The following is a description of a gene set: Mouse Gene Set: MIR_30A_3P_MIR_30E_3P from publication Chen Y, Wang X (PMID 31504780) species: Mus musculus Genes predicted to be targets of miRBase v22 microRNA mmu_miR_30a_3p, mmu_miR_30e_3p in miRDB v6.0 with MirTarget v4 prediction scores > 80 (high confidence targets)., and this is the list of marker genes: Ppp6r2, Sfmbt2, Slitrk3, Kcnb1, Ptpn21, Zfhx3, Slitrk2, Sema3d, Zfp84, Zfp937, 2610528J11Rik, Hcls1, Bche, Zfp612, Pdss2, Relt, Emc4 (ER membrane protein complex subunit 4), Prkacb, Kpnb1, Suco, Trim33, Tmem47, Myo5a, Dgkk, Pde5a, Capn6, Gnl1, Hhip, Dhx9, Magea2, Ninl, 5730480H06Rik, Zfp827, Adamts5, Mecp2, Zc3h14, Rela, Chpt1, Qtrt2, Wrn, Rgs7bp, Slc25a24, Shprh (NCBI Gene Id 70331), Gpr158, Hace1, Hcfc1, Rmi2, Tirap, Sh3gl3, Ccdc80 (coiled-coil domain containing 80), Themis, Macir, Lancl3, Tfrc (transferrin receptor), Nr1d2, Cebpzos, Prkaa2, Ralgps1, Acyp2, Ccdc184, Col12a1, Arid4a, Ube2j1, Ube2g1, Rock2, Csnk1g3, Cpsf2, Ube2f, Trim34a, Anapc10, Zbtb41, Ryr3, Phip, Npy2r, Fat1, 4930579G24Rik, Zfp81, Igf1, Pclo, Rpap3, Tshr, Sun2, Sh3glb1, Hadh, Cdh6, Msr1, Ttpal (tocopherol (alpha) transfer protein-like), Fndc5 (fibronectin type III domain containing 5), Ankrd26, B4galt6, Rala, Aqp4, Arx, Cbfb, Ap4e1, Cdk14, Mcm8, Mug2, Dennd1b, Donson, Lhfpl3, Trhr, Htr2a (5-hydroxytryptamine (serotonin) receptor 2A), Nol4, Lrrtm2, Cep162, Trem1, Col1a2, Luc7l3, Fut9, Ralb (NCBI Gene Id 80581), Itga4, Gne, Mbd1, Hpgd, Csnk1e, Atp8a1, Med12l, Sgms2, Hsf3, Cdadc1, Tnfaip1, Kcna2, Tab3, Rab11fip2, Traf3ip2, Fchsd2, Nufip2, Zfp980, Psd3, Tigd4, Nfkb1, Sh3bgrl2, Papss2, Tspyl1, Cadm2, Slc24a2, Nup153, Ildr2, Fam13c, Hira, Six4, Ttr, Ptpn3, Il1rn, Rgs7, Apc, Rarb, Acsm5, Nap1l2, Stox2, Stau1, Zfp558, Zbtb18, Rtl3 (NCBI Gene Id 213436), Bmp5 (NCBI Gene Id 12160), Lifr, Ptar1, Npffr2, Pno1, Kmt2a, Slc12a6, Hmga2, Etfrf1, Serpine1, Nr2c2, Stim2, Adamts9, Slc25a33, Hmgcll1, Mbnl3, Ror1, Ermn, Rex2, Smim11, Syne1, Antxr2, Atxn3, Ss18, Paip2, Zfp600, Egr1, Cdk17, Tnrc6b (NCBI Gene Id 72625), Pank2, D630039A03Rik, Ppt1, Mnt, Dennd4c, Ccn3, Ssbp2, Erap1, Naa15, Cyth3, Nabp1, Dnajb4, Serpinb8, Tmem140, Cdc73, Ctag2, Robo1, Ipo5, Smu1, Ubr5, Prkd3, 9530002B09Rik, Dock11, Tbx4, Cacybp, Tead1, Tril (NCBI Gene Id 66873), Ccpg1, Pi4k2b, Lcorl, Meox2, Tet2, Fam241a, Ap1g1, Zeb2, Mindy2, Tob1, Eogt, Acad11, Ep300, Pdk4, Il17re, Bccip, Abhd5, Col4a5, Thoc2, Arf6, Camsap1, Ar, Usp1, Dhfr (NCBI Gene Id 71558), Zfp958, Aasdhppt, Zkscan4, Pik3c2a, Cnpy2, Ypel5, Magt1, Chml, Ccnjl, Scai